Given this list of marker genes Tpd52l2, Adcy1 (NCBI Gene Id 52867), Sumo2, Sdc3, Cabp5, Fgfr1, Clstn1, Ikzf4 (IKAROS family zinc finger 4), Chd5, Igf1r, Sall2, Sppl2a, Ehbp1, Bmal1, Pnkd, Thpo, Tpcn1, Tdrd3, Septin3, Pcyt1a, Pm20d1, D430041D05Rik, Rfx3, Pik3r3, Nav1, Lztfl1, Lhfpl4, Jup, Dmd, Vps50, Myh14, Usp11, Npcd, Tox3, Xcr1, Metap1, Ep300, Slc4a8, Pstpip2, Slc22a23, Pgap1, Peg10 (paternally expressed 10), Spry2, B4galt1, Zfand5, Gpc6, Nptxr, Preb, Exoc7, Akap10, Ddb2, Cpxm2, Chrm2, Scimp, Mtcl2, Fam131b, Csnk1g1, Otop1, Fam83h, Dlx3, Adarb1, Tmem86b, Rybp, Gng7, Rgr, Bnc1, Tbx2, Frmd6, Slco4c1, BC048671, Tafa5, Rmnd5a, Tspan33, Fcrl6, here is a description of the gene set: Genes predicted to be targets of miRBase v22 microRNA mmu_miR_5133 in miRDB v6.0 with MirTarget v4 prediction scores > 80 (high confidence targets). Mouse Gene Set: MIR_5133 studied in species Mus musculus from publication Chen Y, Wang X (PMID 31504780)